Given this list of marker genes IGKV1D-33, C4A, IGLV3-16 (immunoglobulin lambda variable 3-16), IGKV1D-12, IGHV3-13, C4B, SARS coronavirus, complete genome, IGLV2-8, IGKV1-12, IGLV6-57, CFP, COLEC11, IGLV3-12, IGHG2, IGHG4, IGLV1-40, IGLV4-60, IGHV3-30, IGLV4-3, IGKV3-15, IGLV2-14, IGLV5-45, IGKV1-16, N, CFB, FCN1, IGLV10-54, MASP2, IGLV3-22, IGHV3-53, C1QA, 3a, IGLC6, IGKV1D-39 (NCBI Gene Id 28893), IGLC2, IGKV1-17, IGKV5-2, IGLV1-44, C1R, IGLV3-25, IGHV4-34, C1S, IGLC1, IGLV2-11, IGLV1-51, IGLV8-61, IGLV7-46, GZMM, MASP1, IGLV1-36, IGLV2-23, IGHV1-69, COLEC10, IGKC, IGLV, IGLV1-47, IGLC3, IGLV4-69, IGKV1-39, IGKV2-29, 7a, IGHV2-70, S, FCN2, IGLV2-18, IGLC7, IGHV3-9, IGHV7-81, IGLV3-1, MBL2, IGKV2-30, IGHV1-46 (immunoglobulin heavy variable 1-46), IGKV1-5 (NCBI Gene Id 28944), IGKV2D-28, FCN3 (NCBI Gene Id 8547), IGKV1-33, CFD, C3, IGLV3-19, IGLV2-33, IGLV7-43, IGHV2-5, IGLV5-37, IGLV3-27, C1QC, IGLV11-55, IGHV, C1QB, IGHG3, CRP (NCBI Gene Id 1401), IGKV3-20, IGHV1-2, IGKV2-28, IGKV3-11, IGKV3D-20, IGLV3-21, IGHV3-48, C2, IGKV4-1, IGHV3-23 (NCBI Gene Id 28442), IGHV4-39, IGHV3-11, IGHG1, IGKV2D-40, E, IGHV3-7, IGKV2D-30, IGHV3-33, M, IGKV1D-16, IGHV4-59 (NCBI Gene Id 652128), here is a description of the gene set: studied in species Homo sapiens part of: Complement cascade Complement activation is due to a cascade of proteolytic steps, performed by serine protease domains in some of the components. Three different pathways of activation are distinguished triggered by target-bound antibody (the classical pathway); microbial polysaccharide structures (the lectin pathway); or recognition of other "foreign" surface structures (the alternative pathway) by C3b. All three merge in the pivotal activation of C3 and, subsequently, of C5 by highly specific enzymatic complexes, the so-called C3/C5 convertases. A complement system with three C3 activation pathways and a common lytic pathway is found only in jawed vertebrates. Reactome Pathway: Initial triggering of complement